The following is a description of a gene set: studied in species Mus musculus from publication Chen Y, Wang X (PMID 31504780) Genes predicted to be targets of miRBase v22 microRNA mmu_miR_12185_3p in miRDB v6.0 with MirTarget v4 prediction scores > 80 (high confidence targets). Mouse Gene Set: MIR_12185_3P, and this is the list of marker genes: Bckdhb, Rbpj, Usp38, Aco2, Lamp2, Sema4a, Klf2, Avil, Zfp24, Panx1, Ret, Rab1a, Atf3, Tbc1d4, Nynrin, Zmynd11 (NCBI Gene Id 66505), Sox5, Med24, Pdik1l, Dner, Ptbp2, Gm5916, Dach1, Kpna1, Melk, Actb, 4930402K13Rik, Nudt7, Hnrnpk, Arcn1, Tbx5, Rbm39, Tmem127, Pate5, Ptprm, Cebpg, Apc, Mtfp1, Zfp711, Dnajc11, Zfp655, Gna13, Zfp418, Cacna1c, Tyro3, Bsnd, Zfand6, U2surp, Lmx1a, Tbc1d2b, Ppp1r26, Rbms2, Cdkl4, Zc3h12a (zinc finger CCCH type containing 12A), Yju2b, Gata6, Bcl9l, Myo1e, Nphs2, Mbd1, Clmn, Arhgap24, Gm11541, Cfap418, Sp1, Tgm6, Iqck, Sv2a, Atf7, Cyb5d2, Sdc4, Csnk1d, Tbl1xr1, Mnt, Pramel47, Cebpe, Ahcy, Stbd1, Tshr, Camk2a, Eif4g1, Hip1r (huntingtin interacting protein 1 related), Cxxc4, Kif21a, Slc25a42, Fam53c, Entrep2, Slc4a8, Ky, Cirbp, Prickle2, Wee2, D5Ertd579e, Eif5a2, Bhlhe22 (basic helix-loop-helix family, member e22), Fam228b, Rbfox2, Phc1, Sec24c, Kif1a, St3gal1, Tcf4, Hspa5, Mapk10